The following is a description of a gene set: species: Mus musculus Mouse Gene Set: GOBP_NEGATIVE_REGULATION_OF_MYELOID_CELL_APOPTOTIC_PROCESS Any process that stops, prevents, or reduces the frequency, rate, or extent of a myeloid cell apoptotic process., and this is the list of marker genes: Ghsr, Fcer1g, Gas6, Stat5b, Itpkb, Il3 (NCBI Gene Id 16187), St6gal1, Ccr5, Cxcr2, Gata1, Selenos, Ccl5, Kitl, Il18, Clec5a, Bcl2, Fcgr2b, Apoh, Nod2, Mif, Stat5a, Maea, Snai2 (NCBI Gene Id 20583), Epo